The following is a description of a gene set: studied in species Homo sapiens A P granule that contains the PIWIL4-TDRD9 module, a set of proteins that act in the secondary piRNA pathway. Human Gene Set: GOCC_PIP_BODY, and this is the list of marker genes: TDRKH, TDRD9, PIWIL4, MAEL, DDX4, GTSF1